Given this list of marker genes KIAA0930, SP6, WDR90, DND1, IPO11, PRKCB, CRTC2, BCL11A, GRB10, HOXA5, HIPK1, NFATC4, MAP4K2, FRMPD4, DAG1, MAP3K11 (NCBI Gene Id 4296), MINK1, ACVR1B, ZFYVE1, SEMA4G, GTDC1, KLF12, PRM1, ZYG11B, DGCR8, SLC6A1, KDM2A, ZIC5, HIC2 (HIC ZBTB transcriptional repressor 2), PMCHL2, HIVEP2, YTHDF3, PHC2 (polyhomeotic homolog 2), CEP41, PRP4K, CMPK1, MAPKAPK2, TEX261, TYSND1, MTF2, LBH, ZFHX2, EMC6, YJEFN3, NFE2L1, PLEKHH2, ZIC1 (NCBI Gene Id 7545), KMT2A, EIF4G2, LZTS3, BTG4, HNF1A, KDM4A, IDO2, LYPLA2, SNN, DLEC1, DPYSL2, DCBLD2, NFKBIZ, PITPNA, PTGER4, PRRT2, HLA-DOB, PTPRE, TAF1L, CENPB, DENND5A, DLL4, FAM13A, MYCBP2, AGO1, PTPRF, CBL (NCBI Gene Id 867), EZH1, TRIOBP, DOLPP1, ZNRF1, HSPG2 (NCBI Gene Id 7796), PCDH7, PMCHL1, TRIM33, EDA, HTT, GAPVD1, NFIA, PGBD5, SCARA3, RAF1, M6PR, LPCAT4, SERTAD1, NAV1, STX5, COL12A1, MROH7, FOXO4, SORBS2 (NCBI Gene Id 8470), ZNF667, TRPS1, DACH1, C2orf68, RETREG1, FGF1, NSD2, PCDH19, here is a description of the gene set: Human Gene Set: GAGCCTG_MIR484 Genes having at least one occurence of the motif GAGCCTG in their 3' untranslated region. The motif represents putative target (that is, seed match) of human mature miRNA hsa-miR-484 (v7.1 miRBase). studied in species Homo sapiens